The following is a description of a gene set: part of: Glycerophospholipid biosynthesis studied in species Homo sapiens Reactome Pathway: Acyl chain remodeling of CL Acyl chain remodeling of cardiolipin (CL) occurs in the inner mitochondria membranes (IM) via hydrolysis by phopholipases and subsequent reacylation by acyltransferases. At the endoplasmic reticulum (ER) membrane the situation is more complicated with monolysocardiolipin (MLCL) involved in hydrolysis and subsequent reacylation back to CL., and this is the list of marker genes: HADHB, TAFAZZIN, PLA2G4A (phospholipase A2 group IVA), LCLAT1, PLA2G6, HADHA